Given this list of marker genes ADRA2A, TRAF5, ARF6, TRAF2, CDC42, TRAF4, TRAF1, RAC1, TRAF3, HAUS7, here is a description of the gene set: Human Gene Set: GOMF_THIOESTERASE_BINDING studied in species Homo sapiens Binding to a thioesterase.